The following is a description of a gene set: studied in species Homo sapiens Any process that modulates the frequency, rate or extent of the PERK-mediated unfolded protein response. Human Gene Set: GOBP_REGULATION_OF_PERK_MEDIATED_UNFOLDED_PROTEIN_RESPONSE, and this is the list of marker genes: TMEM33, AKT2, AKT1, DDRGK1, PPP1R15A, PTPN1, HSPA5, BOK, NCK1, NCK2, PPP1R15B, AKT3, AGR2, ATAD3A, PTPN2, ABCA7